Given this list of marker genes CPB2, KIF20B, AMD1, ARMC8, SART3, BTBD1, SLC2A2, SEMA7A, ILVBL, STAMBP (NCBI Gene Id 10617), TP53I11, MYCN, NPEPPS, HNRNPH1, FAM210A, FAM118A, OMA1, GTDC1, LARP4B, CHEK1, GGH, SLC4A1, RPS6, ELP3, TCHH, NDRG1, RPS6KA4, PTCH1, HSPB8, TIAL1, PATL1, PIM1, CDK1, ADD1, CCNL2, MPO, GCSH, SRSF7, MBD1, INPP5E, RNF4, SAC3D1, C14orf119, KTN1, GABRA2, BTG2, LARP4, B4GALT1, NUDT21, MARK3, RAB11A, NR1H3, DCBLD2, RGPD4, TCF7L2 (transcription factor 7 like 2), PRELID3B, MYD88, APOB, ENTPD4, ADGRF5, ARHGAP5, TNFRSF12A, CHIT1, PLAG1, DYNLT3, DNASE1, RBM17, NRXN2, MECOM, PCNA, TNFRSF10B, SHISAL1, PRKAB2, PIK3CA, ZNF529, PRDX6, PRKAR1B, here is a description of the gene set: Werner syndrome (WS) is a premature aging disorder, displaying defects in DNA replication, recombination, repair, and transcription. It has been hypothesized that several WS phenotypes are secondary consequences of aberrant gene expression and that a transcription defect may be crucial to the development of the syndrome. We used cDNA microarrays to characterize the expression of genes and ESTs across a panel of 15 primary human fibroblast cell lines derived from young donors, old donors, and WS patients. Of the analyzed genes, 6.3% displayed significant differences in expression when either WS or old donor cells were compared with young donor cells. This result demonstrates that the WS transcription defect is specific to certain genes. Transcription alterations in WS were strikingly similar to those in normal aging: 91% of annotated genes displayed similar expression changes in WS and in normal aging, 3% were unique to WS, and 6% were unique to normal aging. We propose that a defect in the transcription of the genes as identified in this study could produce many of the complex clinical features of WS. The remarkable similarity between WS and normal aging suggests that WS causes the acceleration of a normal aging mechanism. This finding supports the use of WS as an aging model and implies that the transcription alterations common to WS and normal aging represent general events in the aging process. Human Gene Set: KYNG_WERNER_SYNDROM_AND_NORMAL_AGING_UP Genes up-regulated similarly in primary fibroblast cultures from Werner syndrom patients and normal old donors compared to those from normal young donors. from publication Kyng KJ, May A, Kølvraa S, Bohr VA (PMID 14527998) studied in species Homo sapiens